Given this list of marker genes RNU4ATAC (NCBI Gene Id 57788), AHCTF1, DOCK5, MED4, CLTA, RNVU1-15, TMEM242, RHOD, GSPT1, TP73, PSMD10, DNAAF11, CLIP3, G3BP2, ICE1, SPTB, NDUFAF6, TRAF2, SMN1, NR1H4, POLQ, C9, SDHAF1, SSH3, DEFA5, ALAD, MED14, HIGD2A, HES1, NOP53, PPP2CB, H3C4, NFE4, PALS2, KCNG2, RPH3A, RRN3, MACROH2A1, MIURF, FADD, KIF18A, PRPF3, CDT1, OGFOD1 (2-oxoglutarate and iron dependent oxygenase domain containing 1), CELF2 (CUGBP Elav-like family member 2), COX16, ATAD2, TUBB4A, BAG4, MMP3, KIF2B, FGF13, PRKCE, TSPY4, NUPR1, TREM2, MLST8, UVRAG, PLEKHG2, ECT2, BAK1, PTGER4, SCO2, NEFL (neurofilament light chain), ZNF207, ATAD2B, RAD51, TAF11L9, KCND3, HDGFL3, PEF1, IKBKG, RBMX, GKN2, TSPY9, KCTD11, WARS1, LIX1L, ARFGEF1, PNLIPRP3, TCAP, H2BC8, KCNB2, TOM1, BID (NCBI Gene Id 637), CENPC, H4C12, STXBP5 (NCBI Gene Id 134957), STING1, NUP98, TRPM4, NDEL1, CREB1, KCTD7, DMAC1, DIAPH1, TAF4, KCTD12, KCNC3, GBP5, GFAP, EIF2S3, TRAPPC4, YAP1, RASIP1, SMARCC2, MOSPD2, CDK5RAP2, DNLZ, SRPK2, THRA, PYCARD, ZNHIT3, PREB, ADCY8, H4C2, FES, RSRP1, COX7A2L, SMYD3, MKKS, H4C3, BOK, SLN (sarcolipin), AGO4, DAXX, UBTF, MRPL58, MRM2, NLRP6, RPL11, KCTD4, WIPI2 (NCBI Gene Id 51623), TFAM, VAMP1, RBPMS, KNTC1, PYDC5, H3C1, MED23, GSN, CIDEB, FERMT1, POLE3, THG1L, PNPT1, TGFBRAP1, MTRF1L, DET1, CRYAB, KIF2C (NCBI Gene Id 11004), CTH, ATP23, H1-2 (H1.2 linker histone, cluster member), NLRP2B, RUVBL1, FUS (FUS RNA binding protein), ITGB1BP1, COX14, KCNT1, SSRP1, HLA-DRB4, TAF11L13, CABIN1, BBC3, CTNNBIP1, DNAI4, H2BC6, RNU5F-1, NDUFS4, USP4, ZDHHC1, DSTN, TRIM32, TTC17, TIMM21, XAB2, RNVU1-1, COA1, SVIP, DKK1, MAVS, MGRN1, MED17, HLA-DQA2, SAMM50, H2BC3 (NCBI Gene Id 3018), CENPO, KCTD14, RPS27L, MAPK8, COPS8 (NCBI Gene Id 10920), CASQ1, GIT1, SNRPE, DMC1 (NCBI Gene Id 11144), PIK3C2A, RPL10L, SF3B6, KAT6B, SMAD7, MT-ND4, ARL2, SETD2, KCNG3, HES5, MCAT, BEND3, TAF2, CYRIA, FNIP1, H4C15, CLIP1, TAPBPL, MPP7, PPID, RNU1-4, TRIM11, BBS10, APOA2, PFN2, STMN1, CCDC88C, KIF5B, CKAP5, SAMD1, MED28, MYH11, SLC1A5, ELN, DNM1L, KCNV1 (potassium voltage-gated channel modifier subfamily V member 1), SLC25A33, SCO1, ATPAF1, BRK1, NAPB, RUBCN, SKA1, PRKCD, TBP, KIF2A, GSPT2, HRG, COX7A1, COX7A2, DNAI1, ABHD17A, NOL3, TRPM2, SHQ1, KIF9, CAMSAP3, NDE1, CENPK, LATS1, HAUS7, BAX, RNU6-1, VTI1B, CHMP4BP1, BOP1, ATG5, UGDH, ODAD1, HEY2, TMED10, TAF1C, HLA-DMA (major histocompatibility complex, class II, DM alpha), CUL3, AFG2B, TAF3, HACD1, NDUFC2 (NADH:ubiquinone oxidoreductase subunit C2), MAPK15, BCL2L11, KCNK13, SNX14, SLC9A1, PRKCZ, TGFBR3, ACSL3, MAP1LC3B2, FCHSD2, KCTD8, COPS7B, RSF1, RAP1B, TAF11L6, PAK3, MAP1S (NCBI Gene Id 55201), ERC2, DNAJC9, TTBK2, RPS14, BIK (NCBI Gene Id 638), H3-4, EIF3J, LIN7A, OCLN, EIF2S3B, SF3A3, ATR, RPF2, CASP4, UQCC5, DNAAF3, LYRM2, H4C6, BRF2, PFDN5, FARSA, TMEM120B, GAS2L2, ZFAND1, CDC42EP2, CLGN, IMMP2L, LUC7L, FKRP, BCL11A, TRAPPC5, TFAP4, DIAPH3, RPS5 (ribosomal protein S5), SMARCA5, DGAT1, CCDC115, HLA-DPB1, ZBTB1, DNAI3, KCTD18, TENM1, STXBP1, LRRC23, APPL2, RPS3, CYBA, SH3BP1, LPL, BRSK1, MIS18A, NEDD1, MDM4, MED18, MIF, TMEM199, NHERF2, KCNA3, KCTD16, CSNK1D, H2BC14, TRAPPC1, RNVU1-19, CPTP, LIPG, UBQLN1, SIGMAR1, CPSF6, DACT1, VTA1, SYNGR3, HAX1, MFSD8, DNAJC17, ACOT13, ELAVL1 (NCBI Gene Id 1994), HLA-A, TAF9, TTN, HIGD2B, CENPW, GABARAPL1, COL1A2, GPIHBP1, ZDHHC8 (zinc finger DHHC-type palmitoyltransferase 8), HIP1, GAS7, UQCC6, RNU5E-1 (RNA, U5E small nuclear 1), ODAD2, NCKAP1L, SETX, PIK3R4, FN1, CIB1, GABARAPL2, TAF11L12, PIAS1, H2BC11, GBP2, KANK4, MITF, PARD3, KCNS3, SPMAP2, DLG5, WIPF1, FGG, WDCP, CD36, LETM1, LCMT1, MACROH2A2, MED8, TWF2, MPO, TSPY8, CASQ2, DNAAF8, TRIM21, OMA1, NCK2, CLN3, MED20, MYC, TTC12, FARP2, APOC3, KRT10, VAMP2, KCTD17, APOA4, FGA (NCBI Gene Id 2243), TARBP2, NDUFAF2, MICAL3, TRIM65, ITPR1, CENPT, TAF1, SLC31A1, MICU1, DNAJC15, SART1, CAPG, EIF3B, KCNA2, VPS39, PFN3, IGF1R, MYD88, DNAH7, TMSB4X, TRPV5, WDR77, ECSIT, CAPZA3, ANKRA2, ATM, MT-ND2, LRP12, FERMT2, SF1, TAF11L10, SURF1, EPS15, CDC45, RTN4, GCFC2, CASP1, APOA5, RNF4, OTOL1, CLINT1, NDUFAF3, INSR, PRRT2, PTK2, STRAP, SPTBN2, EIF3A, MRTO4, PSMB5, CSNK1A1, TAF11L4, NDUFS2, ZC3H12A, APOC2, APOB, BBS12, KCNA5, DMAC2, SART3, PRPF19, KCTD2, VAMP4, HFE, HCN1, ATRX, TNF, SF3A2, KCNC1, KCNS1, KIF25, CFAP100, TSPAN33, PMFBP1, PLEK, DDX20, GNMT, COL16A1, NOP2, SDHAF2, PFN1, PPP1R9B, RHOA, SNRPG, SYT1, SNIP1, BMERB1, SLC7A9, PPP2CA, NUP133, CLNS1A, COX17, UBQLN4, COTL1, PIEZO1, RN7SL2, DNAJC6, IL5, MCOLN1, TBCE, COMP, PEG10, IRGM, SMN2, KMT2D, PSMD5 (proteasome 26S subunit, non-ATPase 5, NCBI Gene Id 5711), VSTM5, NLRP3, TSPYL2, KCNA4, AURKB, UBE2K (ubiquitin conjugating enzyme E2 K), ACACB (acetyl-CoA carboxylase beta), KLC1, PET100, HSCB, OAS1, PRPF18, CELF3, PSMG4, SNRPF, RHOC, ZMYND10, ARL6, TIFA, HMBOX1, H2BC9, SMARCE1, CHAF1B, ASPH (NCBI Gene Id 56921), TRAPPC2, TRABD2B, KANK3, WASHC3, DICER1, DHX9, SPECC1L, CALM1, CHMP3, HMGA1, H1-9P, VPS35, CYLD, ABCG1 (ATP binding cassette subfamily G member 1), MZB1, SPMIP6, NUP205, ALDOA, HIGD1A, SPTBN4, SLF2, NDUFAF5, H2AX, TMEM170A, PTBP2, PDCD6IP, MTLN, COA4, DDX42, TRAF1, KCND1, CCDC65, RPL38, ZMPSTE24, MATN1, STXBP6, FCHO2, H2BC17, MED27, CORO7, HSPA1B (NCBI Gene Id 3304), TAF11L7, MAP1A, MED25, USP50, TAF6, LUC7L2, SNRPA1, TFG (NCBI Gene Id 50989), ARPC3, HCLS1, ANO6, USP16, RN7SL1, ARHGEF7, ARF6, PIN1, TRPV4, PIH1D2, COPS7A, DNAJB14, RPS6, MAT1A, SAMHD1, SRPK1, KCNK6, H1-6, KRT1, RIPK1, TGM2, MET, TLN1 (talin 1), LRRC8D, ARC, SUPT16H, STX1B, EEF2K, NCKAP1, RHO, HCK, UBLCP1, UPB1, CALHM3, VPS18, GEMIN6, DLG1, PLA2G7, ELOB, RPS27, SCAF11, SF3B3, CAPZB, LMOD1, APOC1, PFDN6, HAUS8, PEX14, PICALM, MPP2, AGO2, WDR1, H2BC13, TMOD2, NDUFA6, AIM2, TRIM54, DNAH5, TAF7, PSMD9, MRPS7, ABT1 (activator of basal transcription 1), PYDC1, PEX12, STX17, CHRAC1 (chromatin accessibility complex subunit 1), MTPN, TSPYL5, GLS, TWNK, RYR1 (NCBI Gene Id 906), YME1L1, UBE2C, PEX2, ISY1, H4C8, H2BC4, STMN2, NUP93, DNAJB12, HSF1, COX10, KIF24, TIMMDC1 (translocase of inner mitochondrial membrane domain containing 1), COA3, HSPA1A, NUP35, BRF1, BIN1, PSMG3, EIF3F, TGFB1, VPS33B, KCNB1, CCDC57, CENPX, TEAD1, LCAT, CD2AP, SRP54, MAP7D3, SELP, TP53, EHD1, KCNC4, KCTD15, BECN1, CELF1, NUFIP1, KCNF1 (NCBI Gene Id 9036), EIF4G1, PLEKHH2, LATS2, ANP32B, LGALS3, CENPP, AGTR1, FGB, DNAAF4, CRYAA, RS1, ODAD4, ZW10, FYCO1, APOM, EIF3L, CFL1, HMGB1, ZNF746 (zinc finger protein 746), KCNA6, SRP19, COX20, HAUS4, CLYBL, FBLIM1 (filamin binding LIM protein 1), ACTN2 (actinin alpha 2), VWA1, CELF6, PML, UPF1, H3C3, RPL13A, UBE2S, DNAAF1, RPSA2, DBNL, CBR4, CDC42EP3, LAMC1, BBOF1, SEC16A, H4C11, H3C2, NUP54, RALB, PRMT1, TAF11L11, CARD8, MARK4, SH3PXD2B, MDN1, COA5, CALCOCO2, TAF4B, SEM1, TECPR1, STMN3, MAPRE1, ALOX5AP, NDUFS5, CEP57, PARD6B, ATL3, TMEM39A, BAIAP2, NLRC3, OXA1L, HAT1, MIS12, RUVBL2, LPXN, CSF2, NAA60, ACACA, SMARCD2, SUPT6H, NPHS1, AQP10, AAR2, DYRK3, SRSF6, STOML2, EVL, IAPP, GEMIN4, CYRIB, WASL, WNT3A, CLEC16A, EIF3E, TRPA1, KPNA3, CALY, NRXN1, MED21, ORC4, EIF3I, VPS4B, CHMP4A, CCDC39, TMOD3, SNRPB2, SRPRA, BRCC3, DNAH17, VEGFA, RAC1, EIF5AL1, FANCC, TBCC, H3C12, CDC42EP5, PLA2G2E, ACAD9, RBBP4, NUDT21, H4C16, TIRAP, MCM3AP (NCBI Gene Id 8888), PLA2G5, PRF1, CFAP73, GSDMD, DNAI2, ALDOB, TMEM186, FASTKD2, MID1IP1, H3C10, SEMA5A, FLII, H3C7, TTC9-DT, PEX10, PDXP, ARHGAP27, RNVU1-8, HIP1R, ITGB3BP, KCNRG, AIF1, KANK2, MTOR, NIFK (NCBI Gene Id 84365), NUMA1, SHMT2, OIP5, CHMP2B, CLDN14, CRTC3, SPIDR, U2AF2, KCNC2, TCP1, NEMF, ATP5F1D, EIF3H, GBP1, ANGPTL3, CRACD, YJU2, XRCC5, MTRF1, HSPD1, DLGAP5, SHFL, CENPJ, SSNA1, IL1RAP, EPS8, BIN2, NPM1 (nucleophosmin 1), HLA-DRB1 (major histocompatibility complex, class II, DR beta 1), DNAAF6, TSPYL6 (NCBI Gene Id 388951), CLTRN, ELP6, RYR3, PNLIP, SENP6, TAF7L, H2BC1 (NCBI Gene Id 255626), KCNG4, RAD52, H4C14, FCHSD1, H3-3A, UBTFL6, MSRB1, KCNA10, CADPS2, COL6A1, KIRREL1, LMOD3, NAF1, COA8, CBY1, TAF6L, CENPI, H2AB3, SMARCB1, PRPF39, SNRPC, ENSG00000283175, PIH1D1, SAR1B, HLA-DMB, TTC19, TRAPPC2B, PRPH2, TRAPPC3, NAPG, RDX, CCSAP, DDX3X, MMP1, GEMIN2, CCDC103, SOAT1, NAP1L1, HRK, ME1, CHMP2A, GABARAP, AQP4, SNU13, ITLN1, ERAL1, TGS1, PRMT5, ASF1A, KCNG1, FBXO5, RPS15 (ribosomal protein S15), KCTD6 (NCBI Gene Id 200845), DDX1, H4C9, PAK1, PPP6C (protein phosphatase 6 catalytic subunit), GEMIN7, HAUS6, GNL3L, GSK3B, CORO1A, DDX46, ABCA3, SLF1, RNU5A-1 (RNA, U5A small nuclear 1), HSPA8, RPL24, FAM107A, MT-ND6, PIF1, RNU6-9, TRAF3IP1, ALS2, ANKRD27, DUT, FKBP4, APIP, AQP2, VIL1 (NCBI Gene Id 7429), OGT, VIPAS39, CLEC7A, ZNHIT6, ATAT1, DAB2, KCTD9 (potassium channel tetramerization domain containing 9), MED30, EIF5A, TUBGCP6, SF3B4, NAP1L5 (NCBI Gene Id 266812), EHD4, HLA-DQB2, EFR3A, AQP5, CEP89, RRS1, CD3E, CCDC66, TAF11L8, SDHAF4, PIP4P1, ARPC4, EIF2S2, NCKAP5, CETP, LRRC8C, HTATSF1, MSN, DCTN1, PLTP, VPS33A, ATXN7, BDP1, FHDC1, RBMX2, CYFIP1, ABCA1, PUF60, SV2A, ZDHHC12, TRIM6, RACK1, TUBGCP3, CHCHD4, DDIT4, SUMO1, ARPC5L, SYP, CARD9, HSD17B10, DNAAF5, AP2B1, FCHO1, PYDC2, HOMER1, NDUFAF7, LIX1, APOH, SAR1A, RPL5, PKD2, CATIP, PSMG2, CSF3, FAF2, NAP1L2, SGTB, KRT5, FAU, KRIT1, H3-3B, STMN4, RCC1L, SEH1L, CFAP57, CDK1, HCFC1, HAUS2, VBP1, EIF3G (eukaryotic translation initiation factor 3 subunit G), HAUS3, CAMSAP2, WNK1, TOGARAM1, KMT2A, UQCC1, GAS2L1, IFNG, RNVU1-6, MAP2, MED10, VMP1, GTF2H5, SOST (sclerostin), H1-5, SLC39A12, TRAPPC6A, SHANK1, PDZD11, CENPE, SNRPD1, CAPN3, ANKRD53, H1-10, SNRPD2, TAF11, FER, NCLN, SSBP1, SNAP91 (NCBI Gene Id 9892), HPRT1, SYK, NAP1L6P, SRPK3, BHLHE40-AS1, SCIN, TNFAIP1, PILRB, CCDC63, SRSF5, MED22, KCTD10, CDC42EP1, TBCB, KCNJ2, FNIP2, CD3G (NCBI Gene Id 917), AIDA, NAP1L3 (nucleosome assembly protein 1 like 3), PKD1, BLM, NR4A1, GAK, CCL11, GRIA3, CLP1, KCNN4, ADAR, EIF4B, PSMG1, BNIP3, MAPT (NCBI Gene Id 8152), AGO3, DKC1, SVIL, CDC123 (cell division cycle 123), SF3B5, ALOX15, FMOD, H4C1, CLASP1, MED24, BAIAP2L2, RIMS1, BCS1L, CLTC, MICAL1, ECPAS, OPRD1, IKBKE, INSM1, PARK7, DIAPH2, TUBGCP5, PPP2R5B, CARMIL1, HOPX, PRUNE1, JCHAIN, MIR17, PDCD6, RRP7A, PRMT7, H1-1, CCL21, BLOC1S2, RRM2, VAMP3, H2BC10, SSH1, RNVU1-4, PRKDC, SYCP1, AP2M1, PLEC, ABITRAM, BIRC2, SF3A1, ABCE1, SNRPD3, DNM2, CD2BP2, GEMIN5, PREX1, REPS2, BMF, SRSF1, MTRFR, TPX2, NRG1, PRP4K, ROM1, TFIP11, PTPN22, AGT (NCBI Gene Id 183), PTGES3, TAF12 (NCBI Gene Id 6883), H1-3 (H1.3 linker histone, cluster member), EIF2D (NCBI Gene Id 1939), EIF3C, CDC42, MTG2, KCNQ3, CD40, NDUFAF1, CRYZ, ULK1, CAND1, H1-0, MED1, NLRP1, SCARA5, SNRNP200, H4C7, CALR, KIF18B (kinesin family member 18B), ALDH9A1, RICTOR, KCTD1, MED19 (mediator complex subunit 19), PIK3C3, RUBCNL, EIF2AK2, RPL23 (ribosomal protein L23), RPSA, RPS19, CEP192, PNLIPRP1, CHMP1B, RIOK3, UQCC3, HLA-DOB, TLR4, FASTKD3, LIMA1, TAF1B, PRKRA, UNC13C, KCNS2, GABARAPL3, CDH5 (NCBI Gene Id 1003), CD247, GPX4, RASA1, TRPM7, ARHGAP40, NDUFS3, MTG1, SNUPN, NUBPL, ADD3, MLKL, NFKBIZ, TAPBP, ANGPT1, CCR7, CHAF1A, MAT2A, DARS1, LRRC8A, SPTY2D1, LIPC, TSPY2, ARHGAP28, ADD1, TAF11L3, AFDN, DNM1, ATF1, PSRC1, GRIN2B, TMED2, UQCC2, TNFSF18, B2M, MDM2, CDKN1B, COX15, MT-ND1, TRPV1, KCTD13, EIF6, TBCA (tubulin folding cofactor A), ARPC5, DNAH2, PIK3CA, CHCHD10, VPS11, PHF5A, AQP11, OTX2, DHX30, TUBA1A, CRNKL1, DAB2IP, LAMP2, CHD1, TMEM126A, CELF5, MAP1B, MCM2, MED11, NUP153, CELF4, SMARCD3, APBA1, SF3B1, PCSK6, PRKACA, MAPK8IP2, CREBBP, CRTC2, F2RL1, RNVU1-7, SNAP25-AS1 (SNAP25 antisense RNA 1), CSNK2B, TSSC4, H3C6, PDIA3, TUBG2, TAF11L14, TPPP3, TAL1, STX1A, NFE2, USH1C, NDC1, NSG2, CXCL12, PEX5, NEK7, FANCA, ARHGAP18, CHMP4B, ARID1A, CKAP2, CAMSAP1 (NCBI Gene Id 55490), HIRA, ALDH1A2, TK1, SRC, KIFAP3, RAF1, TESPA1, SNAP29, EP300, KAT6A, MAP6D1, SYNJ1, CHMP6, KANK1, SNAP23, SPAG1, PRPF8, DNAH1, NSF, NDUFAF8, NCK1, ABL1, JAK2, HCCS, KCTD21, KCNA1, AMBRA1, COX7A2P2, HIGD1C, MED16, LMO4, TRPM6, TEKT2, PTPN11, FAS, SNX9, KCNJ12, DNAH8, PON1, POMP, COX18, TMEM126B, CLASP2 (cytoplasmic linker associated protein 2), CUTC, P2RX3, GBA2, CXCL13, SPTAN1, NSG1, CCNB1, HSP90AA1, GRWD1, SH3GLB1, TUBGCP2, SSBP3, KIF14, NVL, SEPTIN8, IFI16, MFSD2A, DNAAF2, BEST1, SPEF1, OSBPL2, PKD2L1, RNU5D-1, WDR47, ATP6V1B1, PXN, RAD51C, TSPYL1, PDE4DIP, GLRA3, PDCL, SPTBN5, MZT1, HLA-DQA1, LRRC61, PCSK5, SPTBN1, SRSF10, TP63, MAP1LC3C, TAF5, GJD2-DT, APEH, PXDN, RRM1, GEMIN8, EIF4H, UQCRFS1, APCS, ADAM10, HMGB2, BRIX1, P2RX7, SSH2, CHMP7, NDUFS8, H2AB2, PPARGC1A, TWF1, BBS4, SMARCD1, CLDN1, KCTD5, HLA-DQB1, SLIT2, LPCAT3, TRIM72, IRAK3, MS4A1, SRSF12, WASHC5, TXNL4A, EXT1, DR1, PINK1, AP2S1, CNTLN, KCTD19, PRKD1, H4C13, PRKACB, CFL2, GTF2A2, APOE, SMARCC1, TMC8, STUB1 (STIP1 homology and U-box containing protein 1), EID2, NAV3, PCNT, KCND2, BUD13, PIK3R2, WASF3, MCTS1, DENR, RIC3, PRMT8, P2RY12, MED29, STMP1, GFM2, RIMS2, EIF3K (eukaryotic translation initiation factor 3 subunit K), KHDC4, HP1BP3, NDUFB3, CARD10, SNAP25, MAPK9, PRNP, EIF5A2, BCL10, NASP, NDUFS7, ADD2, TAF11L2, CENPH, SOAT2, PLEKHA7, MED31, TLR6, NDUFB2, AVIL (NCBI Gene Id 80056), VCP, WASHC2C (WASH complex subunit 2C), BAIAP2L1, SLC2A1, MARCHF5, RNU6ATAC, MCU, SLU7, RRP7BP, ATPAF2, RPS28, LYRM7, MT-CO3, ABCA5, TAF1L, EIF3CL, TPPP2, TTBK1, PPIH, ALDH1A3, AXIN1, TMEM223, PPP2R1A, UQCC4, PCDHGA3, SETSIP, SHKBP1, GTF2B, MAPRE3, CAPZA1, H2BC21, PSMD11, DRC1, PPP1R10, DHX33, SDHAF3, YTHDC1, INPP5J, H1-4, ADRB2, NDUFS1, NDUFA13 (NCBI Gene Id 619501), CX3CL1, RNF135, LSM2, TMEM120A, TSPAN4, TSPYL4, NACC2, H4C5, DMTN, MYADM, COIL, GRIN1, KCNV2, ANLN, METTL17, IFIH1, PLA2G3, ABCA7, TRAPPC11, OPA1, NCKAP5L, VTN, HAUS1, UBN1, RAP1GDS1, APP, IKZF4, MED6 (mediator complex subunit 6), PET117, TMEM9, ARHGEF2, ARPC2 (actin related protein 2/3 complex subunit 2), H2AB1, NLRC4, STEAP4, CCDC40, ANG, TRAPPC8, CLU (clusterin), CAND2 (cullin associated and neddylation dissociated 2 (putative)), WASF1, CTTN, MTTP, LSM4, ADRM1, LONP1, SIRT2, SOD2, PLA2G2A, NCBP1, BAD, DDX23, UNC13A, SLC25A46, TUBG1 (NCBI Gene Id 7283), MSRB2, RNU5B-1, H3C8, HGSNAT, TSPY1, BAZ2A, TMOD4, DNAL1, MED7, KIF19, JMJD4, CHMP1A, EHD3 (NCBI Gene Id 30845), HLA-DRA (NCBI Gene Id 7930), NR1H2, MAP4, AIMP2, CENPA, TMOD1, SRPRB, TAF8 (NCBI Gene Id 135763), DMD, SCAF4, ESAM, AJUBA, LMOD2, GBA1, LARGE1, TACO1, STX4, RAB5IF, PSMC6, ABHD8, PWP2 (PWP2 small subunit processome component), SORL1, TMEM35A, RNF112, BASP1, RIPK2, PRPF31, EML2, HSP90AB1, SMCR8, COBL, RNVU1-14, HAUS5, TPPP, TCF4, TP53BP1, RBM5, NME7, SCAF8, DHX29, VMA21, CCT2, H3C11, CAV3, NAP1L4, CAPZA2, CENPF, CHCHD7, FECH, JAM3, WEE2-AS1, CHMP4C, CLXN, PSIP1, TRPM1, ZRSR2, VAMP7, MEFV, SMIM20, MBD2, COA7, DAAM2, KCNA7, TFRC, RNU6-7, SRSF9, SHPRH, SNAP47, MID1, H1-8 (H1.8 linker histone), TRAPPC2L, CRTC1, ARID2, CCL26, KCTD3, TSPY10, MED9, MT-ND5, USP39, SHMT1, RIMS3, DDX39B, ISG15, TIAM1, VILL, DNAAF10, CARMIL2, CRBN, TRABD2A, FERMT3, CCL24, PLAGL2, CENPV, ETF1, CENPN (centromere protein N), VASP, LRRK2, DLG4, HLA-DOA, MAP1LC3A, H2BC7, H3C15, ATG12, VPS41, H3C14, PRND (prion like protein doppel), NES, HLA-DRB3, EIF5, VAMP8, CDH17, EIF3M, MICALL2, COX19, TRAPPC12, RNU11, TAF10, LUC7L3, NINJ1, ISL1 (ISL LIM homeobox 1), BRAT1, RANBP9, MICAL2, NUP107 (nucleoporin 107), FXR1, TAF13, UBTFL1, EPG5, NAPA, HLA-DRB5, FBXL2, TUBGCP4, AKAIN1, NHERF1, ARHGEF5, RNU4-2, JMJD6, APC, AKAP9, GMNN, SCARB1, STK3, SPP2, SFSWAP, BAZ1A, COA6, SUGT1, SWAP70, ATL2, H2AC25, BTK, SOX9, WNT10B, HSPA5, SET, RNVU1-3, ATP2A2, ZNF827, TICAM1, PRKACG, MED15, GRB2, SNAPIN, VPS16, POLR1E, TAOK1, TBC1D25, SPTA1, SNCA, DYRK1A (dual specificity tyrosine phosphorylation regulated kinase 1A), INF2, TNP1, PTK2B, MECP2, TAF12-DT, HSD17B8, FSCN1, ANGPTL4, PNLIPRP2, PLCG2, ZNF777, FREY1, KCNJ8, HDAC6, ASF1B, APOA1, TBCD, MEGF8, MIR214, TERF1, FARSB, PYM1, PPP1CA, ATL1 (NCBI Gene Id 6681), RB1, RNU2-1, GTF2A1, CYFIP2, NDUFAF4, PTGES3L, PRKN, CARD11, DELE1 (NCBI Gene Id 9812), WDR19, SF3B2, MAP1LC3B, CDC42EP4 (NCBI Gene Id 91740), HIGD1B, RNVU1-17, LLGL1, DDX28, H3C13, APC2, MCTS2, TUBB1, ASB2, WAS, IST1, CALHM1, IL2RB, RNU4-1, HSPA4, KLHL12, FXN, RSPH9, TPR, FMC1, AGO1, ANKS4B, TMEM70, GOLGA2, ODAD3, OTUD6B, VPS8, MIR144, KIF21A, DRG1, SLAIN2, SKAP1, FURIN, DAW1, TRIOBP, PRLR, ITPR3, FOXRED1, PLA2G10, SPAST, LIN54, CHMP5, SNRPB, ESR1, TEAD2, BRD2, VPS4A, HJURP, TBCEL, HLA-DPA1, LCP1, UNC13B, CPSF7, RSPH4A, TRPM3, MCMDC2, HEMK1, C15orf62, ZDHHC5, TRIM31 (tripartite motif containing 31), ATG14, SMARCA4, H2BC15, HLA-G, SLAIN1, EIF3D, MED26, H4C4, KATNB1, NOPCHAP1, POGZ, RN7SL3, PRPF6, PHF23, TSPY3, ARHGAP6, TDO2, AIFM1, NDUFS6 (NCBI Gene Id 4726), TSG101, PADI4, STK4, SLC1A2, RNVU1-2A, MAGI1, TM9SF4, NIN, CD74 (NCBI Gene Id 972), CDK5R1, CHD2, here is a description of the gene set: studied in species Homo sapiens Human Gene Set: GOBP_PROTEIN_CONTAINING_COMPLEX_ORGANIZATION Any process in which macromolecules aggregate, disaggregate, or are modified, resulting in the formation, disassembly, or alteration of a protein complex.